The following is a description of a gene set: species: Homo sapiens Wasting involving the motor neuron. Motor neuron atrophy Human Gene Set: HP_MOTOR_NEURON_ATROPHY, and this is the list of marker genes: PON1, TIA1, UNC13A, NEFH, MAPT, TAF15, DCTN1, SOD1, GLE1, C9orf72, SETX, GLT8D1, HNRNPA1, CPLANE1, PRKAR1B, SQSTM1, AGTPBP1, RBM28, ALS2, CYLD, SPG11, PON2, EXOSC9, TBK1, VRK1, TRPM7, ASAH1, FIG4, SPTLC1, PFN1, SIGMAR1, UBA1, VCP, UBQLN2, PPARGC1A, TFG, KIF5A, CEP126, NEK1, SMN1, ERBB4, PON3, PSEN1, EXOSC8, SMN2, IGHMBP2, DAO, CFAP410, ANG, ANXA11, ATXN2, TUBA4A, SLC25A46, ATXN3, CCNF, VAPB, CHMP2B, TARDBP, TREM2, FUS, CHCHD10, MATR3, OPTN, HNRNPA2B1, EXOSC3, PRPH